Given this list of marker genes GRINA, PGM1, SLC4A7, AP3B1, PC, PHF7, PLP2, AKAP13, WNK1, DCUN1D3, RNF19B, GPBP1, ZNF524, FDX1, GAB2, PTPRK, DRAM2, SEPTIN9, HEATR5A, NABP1, PLPP2, PFN2, PITPNC1, FBXO28, VPS37B, CYB561, FNIP1, PRNP, CDK6, C3orf18, BMP2K, UTRN, GNAZ, RAB11A, TG, TENT5A, CDK17, NF2, DENND5A, HECTD1, XBP1, RIOK3, ZDHHC18, ENO3, NSD3, PIM1, WDR82, MXI1, DUSP22, AGTPBP1, HLA-A, IL10RB, GRIN1, IFT46, MYB, TP53BP2, CA13, BTG1, PHF6, SPAG9, COBLL1, TRAF6, COX17, SPRY1, EDEM2, SOCS3, DNAJC30, GTF2B, SLC39A10, POLI, PRELID2, BMPR2, ARHGEF3, HROB, STRADB, MBD2, IL2RA, ACSL4, RASA1, FYN, USP22, CASTOR1, DCAF7, FCMR, RRAGD, FASLG, PEX1, LTA, B4GALT1, PRDM2, C9orf85, HIBADH, THEMIS, RABGAP1L, RRAS, RAD52, EPS15, RGS1, SSH2, MIER1, CD53, EZH2, ZC3H12D, GPKOW, LYRM1, DOCK10, H3C7, TMEM237, REXO5, HEY1, NR4A3, CLINT1, IL24, IL7R, ST3GAL4, LYST, H3C14, CD44, FAF1, MIF, MAPKAPK2, APLP1, TMEM131L, ADPRH, BICDL1, CAST, SH3GLB1, TMEM184B, TMEM158, HBEGF, HIPK2, MDFIC, TRPC4AP, LETMD1 (NCBI Gene Id 25875), CAPN5, POU6F1, PLA2G12A, IRF4, TMEM107, SDF4, AFF1, RAB34, SMARCE1, RASGRP1 (NCBI Gene Id 10125), FBXO17, TET2 (tet methylcytosine dioxygenase 2), PTGER2, ZNRF3, GPR146 (NCBI Gene Id 115330), MGAT4A, RGCC, RNF11, MLLT3, MAN1A1, NDRG2, SCARB2, SMOX, PRICKLE1, ITGA6, CCNC, TPD52, MTMR3, NFKB1, AFDN, RYBP, OSM (NCBI Gene Id 5008), SELP, TMCO3, CAMSAP2, TAX1BP1, ICOS, REV3L, OXLD1, CSRNP1, SYTL1, MYC, RBM17, GALC, RAP1GDS1, NRN1, ANKLE2, DIPK2A, CISH, GALNT3, CLPX, SH2D1A, SAP30, YAF2, GSTT1, CYSLTR1, ABHD17B, DLGAP4, FOXO1, CAPN2, MPZL2, KDM3A, TEX2 (testis expressed 2), ANXA3, ARID5A, BCL2L2, here is a description of the gene set: We have previously shown that rheumatoid factors (RF) produced by Fas-deficient autoimmune-prone mice typically bind autologous IgG2a with remarkably low affinity. Nevertheless, B cells representative of this RF population proliferate vigorously in response IgG2a/chromatin immune complexes through a mechanism dependent on the sequential engagement of the BCR and Toll-like receptor 9 (TLR9). To more precisely address the role of both receptors in this response, we analyzed the signaling pathways activated in AM14 B cells stimulated with these complexes. We found that the BCR not only serves to direct the chromatin complex to an internal compartment where it can engage TLR9 but also transmits a suboptimal signal that in combination with the signals emanating from TLR9 leads to NF-kappa-B activation and proliferation. Importantly, engagement of both receptors leads to the upregulation of a group of gene products, not induced by the BCR or TLR9 alone, that include IL-2. These data indicate that autoreactive B cells, stimulated by a combination of BCR and TLR9 ligands, acquire functional properties that may contribute to the activation of additional cells involved in the autoimmune disease process. Human Gene Set: GSE6674_PL2_3_VS_ANTI_IGM_AND_CPG_STIM_BCELL_DN from publication Busconi L, Bauer JW, Tumang JR, Laws A, Perkins-Mesires K, Tabor AS, Lau C, Corley RB, Rothstein TL, Lund FE, Behrens TW, Marshak-Rothstein A (PMID 18025183) species: Homo sapiens Genes down-regulated in B lymphocytes: PL2-3 (Chromatin IC) versus anti IgM and CpG oligodeoxynucleotide 1826.